Given this list of marker genes Stk17b, Bbc3, Trp63, Men1, Bid, Nupr1, Sfrp1, Prdm11, Btg1, Bcl2l11, Socs1, Pmaip1, Apc, here is a description of the gene set: Mouse Gene Set: GOBP_POSITIVE_REGULATION_OF_FIBROBLAST_APOPTOTIC_PROCESS Any process that activates or increases the frequency, rate or extent of fibroblast apoptotic process. species: Mus musculus